Given this list of marker genes Dpyd, Dut, Upp1, Dpys, Dctd, Nt5m, Upb1, Nt5c3, Nt5c, here is a description of the gene set: The chemical reactions and pathways involving dUMP, deoxyuridine (5'-)monophosphate (2'-deoxyuridine 5'-phosphate). species: Mus musculus Mouse Gene Set: GOBP_DUMP_METABOLIC_PROCESS